Given this list of marker genes Stat3, Alox5 (arachidonate 5-lipoxygenase), Reg3g, Mdk, Siglecg, Cd24a, Git1, Grn, Extl3, Ptpn6, Dsg2 (desmoglein 2), Il17a, Il33, Reg3a (regenerating islet-derived 3 alpha), here is a description of the gene set: species: Mus musculus Mouse Gene Set: GOBP_REGULATION_OF_INFLAMMATORY_RESPONSE_TO_WOUNDING Any process that modulates the frequency, rate or extent of the inflammatory response to wounding.